The following is a description of a gene set: Human Gene Set: LAKE_ADULT_KIDNEY_C11_THIN_ASCENDING_LIMB species: Homo sapiens from publication Lake BB, Chen S, Hoshi M, Plongthongkum N, Salamon D, Knoten A, Vijayan A, Venkatesh R, Kim EH, Gao D, Gaut J, Zhang K, Jain S (PMID 31249312), and this is the list of marker genes: NFAT5, ASCC3, LINC-PINT (long intergenic non-protein coding RNA, p53 induced transcript), BICC1, FOXP2, RBM47, TRPS1, SOD2, MT2A, VMP1, THRB (NCBI Gene Id 7068), S100A6, USP53, SLC4A7, MTUS1, ELF2, COL18A1, NRXN3, CDC42BPA, SIK3, VPS13C, BRD10, ARHGAP24, PFKFB3, LAMB1, PCSK6, PLOD2, CTDSPL, MAGI1, FAM135A, SLC16A7, KCNIP4 (NCBI Gene Id 80333), VPS13B, IVNS1ABP, SVIL, TPST1, DNAH5, BCL6, EXT1, RUNX1, PACS1, EIF4G3, CPM, GALNT14, KAZN, ATP1A1, CACNA2D3, LRBA, ITGB6, PDE1A, PLEKHA1, PCDH9, QKI, FOXP1, AFF1, ZFAND3, WWC1, NCOA7, DNAH14, ZEB1, PRKD1, LINC01320, PRKCE, SASH1, SPP1, ADAMTS1 (ADAM metallopeptidase with thrombospondin type 1 motif 1), SAMD12, TENM4, NEAT1, PIBF1, MGLL, NIPBL, RALGAPA2, STK3, SERPINA1, GRAMD2B, FNIP2 (folliculin interacting protein 2), ZMYND8, GLIS3 (NCBI Gene Id 648268), C4orf19, ITPR2, PLCB1, CA10, MED13L, SAT1, ZNF385D (NCBI Gene Id 79750), GOLM1, LRRFIP1, TRIO, MAGI3, OR7E14P, SDCCAG8, ADAM10 (NCBI Gene Id 102), TMTC2, MECOM, ITGA2, ARHGEF28, HIF1A, ADK, ERRFI1, GPC6, TRIM2, SAMD4A, HIVEP2, IMMP2L, ERBIN, UBE2H, SPIDR, NOS1AP, MYO1E, PITPNC1, PTPRG, ADAMTS9, CRADD, GCC2, EFNA5, PLEKHA7, TRA2A, PPP2R3A, ETV6, TFPI, PTK2, RIMS2, TBC1D5, TBCK, MAST4, MKLN1, RFX3, TCIM, TNS3, UGT2B7, CLDN10-AS1, CAMKMT, CDH16, MSI2, ZSWIM6, BRWD1, MYO9A, DDX5, KIAA1958, NEK10, FCHO2, TANC2, OSBPL3, NCOA2, EEF1D, ALDH1A2, SSBP2, NCOA1, DOCK1, FBXL17, TRAPPC9, RBMS1, ARHGEF3, PDE7B, LPP, AHI1, RUFY3, PRDM16-DT, SNED1, RASSF8, UGGT2, ACADVL, PHF21A, DIP2C, PAX8 (paired box 8), KIF13B, SGIP1, YAP1